Given this list of marker genes Nudt5, Nt5c1a, Upp2, Xdh, Entpd2, Nudt9, Upb1, Nudt1, Nt5c1b, Entpd8, Adprm (ADP-ribose/CDP-alcohol diphosphatase, manganese dependent), Pnp, Nt5m, Dpyd (dihydropyrimidine dehydrogenase), Nudt15, Entpd4b, Nudt18, Itpa, Gda, Nudt16, Entpd3, Upp1, Entpd5, Entpd6 (NCBI Gene Id 72561), Tymp, Nt5c2, Dnph1 (NCBI Gene Id 98052), Entpd4, Pnp2, Dpys, Entpd1, Samhd1 (SAM domain and HD domain, 1), Nt5c3, Entpd7, Nt5c, Nt5e, here is a description of the gene set: Nucleotide catabolism species: Mus musculus Mouse Gene Set: REACTOME_NUCLEOTIDE_CATABOLISM